Given this list of marker genes Mt1, Vav1, Rtn4, Srgn, Septin3, Cd207, Elovl1, Cd9, Plpp1, Mtmr4, Sf3b3, Cd53, Rtn1, Pfkp, Spi1, Rnf166, Tm6sf1, Ifitm2, Atp1a1, Timm10b, Ucp2, here is a description of the gene set: from publication Cui A, Huang T, Li S, Ma A, Pérez JL, Sander C, Keskin DB, Wu CJ, Fraenkel E, Hacohen N (PMID 38057668) species: Mus musculus Genes positively differentially expressed in cell type: cDC1 (conventional dendritic cell type 1) upon treatment with cytokine: SCF in mouse lymph nodes in vivo. Cytokines mediate cell-cell communication in the immune system and represent important therapeutic targets. A myriad of studies have highlighted their central role in immune function, yet we lack a global view of the cellular responses of each immune cell type to each cytokine. To address this gap, the authors created the Immune Dictionary, a compendium of single-cell transcriptomic profiles of more than 17 immune cell types in response to each of 86 cytokines (>1,400 cytokine-cell type combinations) in mouse lymph nodes in vivo. A cytokine-centric view of the dictionary revealed that most cytokines induce highly cell-type-specific responses. For example, the inflammatory cytokine interleukin-1β induces distinct gene programmes in almost every cell type. A cell-type-centric view of the dictionary identified more than 66 cytokine-driven cellular polarization states across immune cell types, including previously uncharacterized states such as an interleukin-18-induced polyfunctional natural killer cell state. Mouse Gene Set: CUI_CDC1_SCF_RESPONSE_UP